The following is a description of a gene set: from publication Fu W, Ergun A, Lu T, Hill JA, Haxhinasto S, Fassett MS, Gazit R, Adoro S, Glimcher L, Chan S, Kastner P, Rossi D, Collins JJ, Mathis D, Benoist C (PMID 22961053) Human Gene Set: GSE40274_CTRL_VS_EOS_TRANSDUCED_ACTIVATED_CD4_TCELL_UP species: Homo sapiens Genes up-regulated in CD4 T conv: control versus over-expression of IKZF4. The transcription factor FoxP3 partakes dominantly in the specification and function of FoxP3+ CD4+ T regulatory cells (Tregs), but is neither strictly necessary nor sufficient to determine the characteristic Treg transcriptional signature. Computational network inference and experimental testing assessed the contribution of several other transcription factors (TFs). Enforced expression of Helios or Xbp1 elicited specific signatures, but Eos, Irf4, Satb1, Lef1 and Gata1 elicited exactly the same outcome, synergizing with FoxP3 to activate most of the Treg signature, including key TFs, and enhancing FoxP3 occupancy at its genomic targets. Conversely, the Treg signature was robust to inactivation of any single cofactor. A redundant genetic switch thus locks-in the Treg phenotype, a model which accounts for several aspects of Treg physiology, differentiation and stability., and this is the list of marker genes: ADAMTS14, CDCA2, F2R, HSPA4L, KIF18B, ALDOC, DEPDC1, SPRY2, PDE4A, RAP1GAP2, TPX2, NAGA, CDK2AP1 (cyclin dependent kinase 2 associated protein 1), OXR1, RAP1B, ATP13A2, DLGAP5, TACC3, AS3MT, CMKLR1, PACSIN2, CNNM2, IL12RB2, SGO2, TRAF3IP1, PLCH1, RNASEK, ESM1, SESN2, KIF14, BIRC5, MASTL, CDC20B, SH3BGRL3, ERN1, ITGA2, SLC48A1, CKAP2L, SGO1, ECT2, MID1IP1, IFNGR1, TTK, MIR106A, MKI67, APOBEC2, CCNA2, SMPDL3B, ASF1B, NDC80, H4C6, TBC1D31, H2AC15, PRDM1, EPAS1, VKORC1L1, IFNG, GZMK, BUB1, NCAPH, CDCA3, STMN1, NRARP (NCBI Gene Id 441478), ANLN, MAP3K8, FGL2, ZMIZ1, SPAG5, GALNT3, H1-5 (H1.5 linker histone, cluster member), SEPTIN11, DCLRE1A, HAVCR2, ERP44, SNX5, CTU2, CASP7, KCTD13, AK3, ADRB2, HMMR, GZMA, KIF15, IL18RAP, DPCD, DUSP5, RACGAP1, ESCO2, GEN1, SEMA4F, DAPK2, KLHL15, DUSP16, PLCG2 (phospholipase C gamma 2, NCBI Gene Id 5336), RB1, NASP, PDE8A, MIR17, SNX10, FIGNL1, PLEK, CHSY1, ARSB, MYBL1, MIR188, STIL, SHCBP1, ITGAM, KLRG1, FCGR2B, KIF18A, CDCA8, CLSPN, UBXN2B, INSL6, SMIM11, ELOVL7, KNTC1, SLC43A3, CCL4, CDC25C, H2BC3, CDKN2C, SPAG1, ARHGDIG, STARD10, LGALS3, E2F2, AURKB, NUF2, CREB3L2, TBX21, TOP2A, FAM78B, PON3, CIT, MAD2L1, KIF22, GOLIM4, IKZF3, KNL1, LRRK1, SP100, POLD1, GNS, GZMB, GTSE1, ANXA1, RAPH1, LAT2, CDK1, CCL3, KIF11, PRC1, NEIL3, GPX8, ITGA1, CDCA5, FOSL2, TCF19, SPC25, SUMF1, BHLHE40, SEPTIN4, KIF23, TMEM170A, ATOH1, ATP1B1, CENPI, CX3CR1, FRY, CLNK, DTL, RAD54L, ZEB2, ARL6IP4